Given this list of marker genes ATPAF1, ITCH, COQ5, SNRPD3, TRPC4AP, FBL, SNX19, HAX1, GET4, ENSA, MRPS2, RPA1, SLC35A4 (NCBI Gene Id 113829), COA5 (NCBI Gene Id 493753), GTPBP1, EIF2S2, SMARCA5, PTPN11, TSPYL1, CHMP2B, KRAS, WHAMM, PSMC3, RUVBL1 (RuvB like AAA ATPase 1), SPAG7, DNAJC8, USB1, LTV1, ARFGAP2, QRICH1, POLR1D, TBL1XR1, FLCN (NCBI Gene Id 201163), CDC34 (cell division cycle 34, ubiqiutin conjugating enzyme), PPIB, SENP2, SMARCC1, ARCN1, EMC4, SUB1, BUB3, VPS16 (VPS16 core subunit of CORVET and HOPS complexes), E4F1 (NCBI Gene Id 1877), NFX1, SLIRP, COX15 (NCBI Gene Id 1355), OXSR1, CYB5B, TERF2IP, FAF2, USP39, PSMD7, AK2, IPO9, DHPS, DNAJB6, BSDC1, UBQLN1, FAM168B, C1orf174, NSMCE4A, TIMM22, BORCS7, H2AZ2, EIF3M, CACTIN, JAK1, GNL2, TNKS, FBXO28, NOP14, SF3B2, ERGIC1, STX4, DNAJA1, SEC62, STK24 (serine/threonine kinase 24), PPID, LSM4, APPL1, BTF3, MEA1, OTUD4, MRPS30, HNRNPA1, PRDM4, PA2G4, SCYL2, C11orf98, PRPF38A, EMC6, PRKAA1, WASL, BAP1, SF3B6, UBE2F, UBQLN4, FZR1, FAM168A, SNF8, YARS1, ACBD3, TOMM20, OST4, MIEF1, ATF6B (activating transcription factor 6 beta), AKIRIN1, RANBP1, RALY, TMEM245, TAOK2, MRPL57, ARAF, LSM14A, ZMIZ1, SH2B1, PDAP1, MECP2, DNAJC1 (DnaJ heat shock protein family (Hsp40) member C1), ZNF146, TADA3, EIF4G2, RBM42 (RNA binding motif protein 42), UBE3C, CUL3, BRMS1, TAX1BP1, DCTN3, SENP5, ZNF706, HAPSTR1, EIF2B1, ZNF865, BRK1, ANP32A, EIF3G, USP48, UFL1, SNRNP70, SPG11, PSMA5, DNAJC4, PBX2, VCP, RNF139, GTF3C3, SON, PHRF1, PCGF3, RNF216, DCTN2, CDK4, CSNK2B, TMEM248, TIMM17B, KPNA4 (NCBI Gene Id 84857), ZDHHC6, DHX40, YWHAQ, FEM1B, COMMD7, NMD3, RAD21, COPS5, H3-3B, THOC7, JAGN1, EEFSEC, ERH, SKP1, SNX3, MAX, CHMP4B, MRPL9, LAMTOR5, METTL9, MBD2, MRPL41, WDR45B, SEC13, MCMBP, ZC3H3, KDM4B, DCTN4, C1orf43, RABGGTB, UBE2Q1, GOLGA3, CALR, ARMCX3, PPP1CC, ISCU, NIFK, JOSD1, COA3, HMGXB3, TOMM22, POLR3C, RC3H2, RANBP10, PSMD6, OSTC, SOD1, ATG3, TSR1, NT5C2, CTNNBL1, COASY (Coenzyme A synthase), COPZ1, NDUFB8, UTP18, MYCBP2, MFN2, HSPA4, PDCD7, RALBP1, RAB11A, RHOT2, PLAA, SRPRB, PARK7, FAM98A, PPP1R11, PUF60, ST13, KCMF1, MGRN1, NUMA1, RPL22 (ribosomal protein L22), TMEM203, DDX1, HSP90B1, SP1, ANKRD52, ANKS1A, MRPL51, CDC5L, RBM8A, CLNS1A, NAPG, LCMT1, NGDN, PHF5A, AGGF1, VEZF1, SMAP1, GTF3A, SNRPB, PSMD11, PPP2R1A, MRPL44, ZC3H18, MORF4L2, USP14, DRG1, SNRNP35, MTDH, ABCE1, NSMCE1, MAZ, EIF5B, RBM25, API5, MED4, LRPAP1, POLR2K, GBF1 (golgi brefeldin A resistant guanine nucleotide exchange factor 1), CREBBP, VPS37C, GOLGA4, SLC39A6, PPP2R5A, AAMP, PACS1, CNOT11, GTF2F1, LMF2, CMTR1, MLEC, SMC1A, MRPS16, CLPTM1L, PURB, PNRC2, YTHDC1, DNAJC11, EMC8, LSM12, CTDNEP1, DHX15, GTF2B, NXF1, ARHGAP1 (Rho GTPase activating protein 1), VPS26A, STK38, LONP2, SPPL3, PSMD14, BRD3, CBX1, OTUB1, LAMTOR1, MAPK1IP1L, GDI2, UBFD1, CDKN1B, WAC, TIMM17A, MBD1, AHSA1, CRKL, SF3A2 (splicing factor 3a subunit 2), RRP7A, JTB (jumping translocation breakpoint), TMEM165, AIDA, SP2, SETD5, EIF4A3, DDX17, MRPL36, ATF6, FIS1, IK, PFDN1, RAB35, SRSF11, CBY1, SSR3, FAM32A, SRSF4, EMD, TMEM50A, BZW1, ZMYND19, UBE2Z, TMX4, SNX12, COPB2, MCCC2, MRPL22, SFPQ, AKT1, CHP1, BAG1, ELK1, G3BP2, ERAL1, TBK1, DNTTIP1, RANBP9, LONP1, BRD4, ZFYVE21, LSM14B, MRPS25, CUL4B, GUK1, PPP6C, SLC25A11, PAFAH1B2, RNF113A, EIF3K, USP22, PDS5A, SF3B4, APEH, BUD31, CLPP, MED28, B4GALT7, AARSD1, RRP9, U2AF2, ARF1, HNRNPUL2, MRPL49, TPP2, PREB, CIPC, PTEN, LMAN2, TUBG1, CLPTM1, PIN1, FBXW5, HNRNPA2B1, HSPE1, PELP1, LEMD2, PSMA7, PACSIN2, EIF4H, DDX23, CCT4, UBAC1, SART3, OS9, PABPN1, NUP153, LMAN1, HTATSF1, PSMD8, PAIP1, BET1L, CMPK1, ABCF2, EIF1AX, MSL2, FAM50A, CDC16, TMEM230, RMND5A (NCBI Gene Id 64795), MAU2, SMDT1, ZC3H11A, NAP1L4, NCL, RNF181, RANBP2 (RAN binding protein 2), PBDC1, MMADHC, ILF2, MORC2, TMED10, TPI1, GPX4, SRSF2 (NCBI Gene Id 6427), RAB11B, NAT10, COPS4, BNIP3L, EBNA1BP2, SMPD1, COX17, PSMA6, SLC35E1, KDELR2, PMPCA, SLC25A3, NUDT21, ZRSR2, LARP1, WDR83OS, POLD2, KCTD20, HCFC1, ARFGAP3, GPI, NMT1, ERLEC1, G3BP1, DNAJA3, GOSR2, NGRN, RPL4, SEC24B, ALDH9A1, TSR3, RTCB, DDB1, ATP5PF (NCBI Gene Id 63498), PCIF1, PCSK7, RSRC2, INTS12, NCBP2, ARL8B, SNX27, APH1A, LAMP2, RBM14, PGRMC2, HGS, NUDC, RBCK1, EIF2AK1, EIF1B (NCBI Gene Id 10289), RRAGA, ACAD9 (NCBI Gene Id 96656), TMCO1, SLC25A28, CDC42SE1, AGAP3, MORF4L1, TXNL1, CUTA, PRPS1, WIPI2, SRRM1, NSA2, TAF10, STRAP, ARPP19, RAB14, PSME3, MAN1A2, ZNF593, OGT, PTRH2, STUB1, UBR4, FUBP3, SSNA1, DNAJC7, POLR2J, FCF1, NARS1 (NCBI Gene Id 9243), CDC37L1, PSMB6, COPG1, RER1, PRCC, CAB39, C9orf78, PUM2, NELFB, GTF2F2, MED13 (NCBI Gene Id 9969), INO80, SBDS, RPL15, PGAM5, FKBP8, SRM, SRP14, KDM1A, GTF3C6, UBAP2L, ATP6AP2, ELOF1, TAB1, ERGIC3, PCMTD2, SEC31A, PSMC1, CNBP, TRIM28, ALKBH5, HNRNPAB, PAF1, SLC30A5, ATP6V0E1, DAP3, BTBD1, PARN, SPAG9, ANKFY1, BOD1, CUL1, MEPCE, SNAPIN, LSM1, SEPHS1, PSMD5, TBCA, RPL35A, MRPS17, GSPT1, DENND6A, VPS25, DPY30, CDC23, SAR1A (NCBI Gene Id 56909), CSNK1G2, ZBTB17, SCYL1, ARNT, GID8, NOB1, TMEM256, DDX47, AK3 (NCBI Gene Id 50808), BAZ1B, TCP1, ERP44, RRN3, CTBP1 (NCBI Gene Id 1487), MRPL28, EIF3A, NUCKS1, TMEM42, C6orf120 (chromosome 6 open reading frame 120), RPA2, AP1G1 (adaptor related protein complex 1 subunit gamma 1), PSMD4, HDLBP, ZNF777, EIF3E, NUDT16L1 (NCBI Gene Id 84309), UBE2J1, BANF1, SYF2, HNRNPUL1, EXOC2, HSD17B12, CEBPZOS, MED9, SREBF2, CCT2, EMC2, CFDP1, MAPK1, NFYB, POLR2C, HINT1, HTT, PPP5C, UBL4A, DNAJC5, NAP1L1, G6PC3, SRP9, EIF2D, TXNDC12, GSK3A, MTFR1L, EAPP, MCTS1, CD2BP2 (CD2 cytoplasmic tail binding protein 2), UBE2I, DIMT1, SSR2, SND1, CCAR2, STIM1, MRPS14, UBL7, BLOC1S2, AKIRIN2, DARS1, KHSRP, TBC1D20, SPG7, YME1L1, MAPK8IP3, E2F4, PATL1, MSL1, RING1 (NCBI Gene Id 6015), STIP1, TUSC2, RNF20, TMEM219, AASDHPPT, PARP1, GNPTG, SLC25A5, DNAJC9 (NCBI Gene Id 23234), GATAD2B, RPS19BP1, ILF3, TXN2, PSMC5, GPKOW, KIFBP, PPP6R2, LARS1, FAM20B, PSMG2, TOMM70, PFDN2, ADIPOR2, ARL14EP, TMEM101, VPS52, CNPPD1, CCZ1, DERL1, PNO1, VPS36, ACTR2, MRPL37, FHIP2A, SMAD2, DCAF15, ATG101, EIF4B, NDST1, CSNK2A2, SKIC3, SF1, FBXL3, SMIM12, FIZ1, MRPS28, SH3GL1, TMEM258, LENG8, DEAF1, SYNCRIP, ACTR1B, CCDC97, TCF25, TOR1B, HP1BP3, ARMC1, SDHAF2, CUEDC2, BCAP31, LDB1, DAD1, PRDX5, RAB2A, C14orf119, EDC3, RAB7A, FBXO42, DDX18, IQSEC1, KPNA3, PWP2, AARS1, NUP133, MRPS9, SHARPIN, UGP2, CCDC47, IGBP1, GLE1, SART1, SGTA, KBTBD2, GNB1, TEX261, YWHAB, CTNNB1, TUT1, CGGBP1, PCMT1, PPTC7, PSMD10, PRPF18, KLHDC10, TMED4 (transmembrane p24 trafficking protein 4), CHMP3, C6orf89, SERBP1, CDC123, TMEM127, ANAPC2, PDIA6, PSMD1, DCTPP1, SNX1 (sorting nexin 1), VTI1B, NOP9, KDELR1, STRN4, OSBP, U2AF1, NRBP1, RANGAP1, MRPL14 (NCBI Gene Id 64928), SRSF6, FXR2, PRPF19, CMAS, NOL7, PSMB2, SMIM11, BTBD2, LENG1, SMARCB1, RNF167, AAR2, PSMD3, VPS26B, KHDRBS1, RAB1B, STAU1, WBP4, THRAP3, RSL24D1, KIAA0319L, SURF4, UROD (NCBI Gene Id 7389), SARS1, PRKRA, MRPL18, CSNK2A1, PIGH, CDC37, EEF1D, RAD23B, UBP1, VDAC1, IER3IP1, DYNC1LI1, STAT3, PCYT1A, TNKS2, PPP2R5C, SEC61B, ARL6IP1, RERE, ASNSD1, KEAP1, PSMB7, CDC42, GPBP1, DCAF12, RNF168, RAB5A, CHTOP, PPP1R37, SRSF9, ILKAP, WRNIP1, GNPAT, TARDBP, TRAM1, RAD23A, R3HCC1, TBCD, LYSET, PAFAH1B1 (platelet activating factor acetylhydrolase 1b regulatory subunit 1), YTHDF1, SAV1, EBAG9, RBMX2, GABARAPL2, MYDGF (NCBI Gene Id 80302), MARCHF5, EPN1, LRPPRC, ARF4, SRSF3, COMT, PCYOX1 (NCBI Gene Id 63081), RARS2, ACBD6, SSBP1 (NCBI Gene Id 6742), SLC35A1, CASC3, RALA (NCBI Gene Id 5898), SLC4A1AP, YIF1A, PCBP2, THAP11, SF3B1, HNRNPM, SMU1, NDUFAF2, UBL5, SUPT6H, MED10, ZDHHC7, STK11, GSTO1, CRTC3, COPE, RABL6, EIF3B, RAB6A, HIGD1A, NEDD8, SUGT1, PDCD6, LRRC59, ARPC2, TOLLIP, NFATC2IP, TMBIM6, YIPF3, ADRM1, CCNI, HIPK1, HAT1, GOLPH3, INTS10 (NCBI Gene Id 55174), TMX3, PPT1, ICMT, LUC7L3, UBXN1 (NCBI Gene Id 92151), CCDC22, MRPL24, ANKLE2, PRKAR1A, MRPS10, MRTO4, AP3S2, DENR, CRK (CRK proto-oncogene, adaptor protein), CDC26, BAD, YWHAE, RAC1, LRRC41, TRMT112, BMI1, POFUT1, KAT8, KXD1, KCTD5 (NCBI Gene Id 91152), ANKRD10, SERP1, DNAJC13, AIP, PSMB4, SCAF1, SLC30A9, SAP18 (NCBI Gene Id 10284), ZFP91, FIBP, EIF2S1, MAP2K2, TMEM183A, EMC7, ARL1, TMEM60, MTPN, ACTR1A, SRSF1, NPEPPS, TRIP4, NAPA (NCBI Gene Id 8775), STX8, ZNF330, DDX19A, NUDT9, HNRNPDL, EIF5A, SSU72, VPS29, IPO8, RNPS1, BCCIP, BFAR, CSNK1D, P4HB, PPP2R5E, IWS1, HSP90AB1, MRPS5, ISCA2, ELAVL1, ZRANB2, DYNLRB1, IPO5, HNRNPD, HERPUD2, PDPK1, UTP3, CFL1, TM9SF3, MPHOSPH10, SMYD5, TMEM30A, SARNP, TMED1, NUS1, MAGOH, PWP1, YY1, HSF1, PSMA2, MED25, MTCH1, MTOR, PPP1R15B, COPS6, GATAD1, MLF2, HSBP1, BLTP2, SNRPA, DDX51, CCDC50, TBCB, DNAJB11, EXOSC4, DCAF5, RBX1, PHF12, USP4, TSN, KARS1, SSRP1, PRKAR2A, PREP, MRPL38, UBA1, RPL7L1, FTSJ3, GPN3, MFSD14A, WDR55, EIF3D, GET3, SUMO1, ETF1, VPS51, GFUS, MAPRE1, SPRYD3, ERI3, KPNA6, PIP5K1C, MAEA (macrophage erythroblast attacher, E3 ubiquitin ligase), CEBPZ, PSME3IP1, BTF3L4, NCOA5, CSNK1A1, TMEM259, TADA2B, BAG6, RTF1, POP7, CHMP6, ZC3H15, RPN1, SDF4, DHX38, PSMG3, AMFR, HNRNPU, PSMB1, ANKRD40, COG7 (component of oligomeric golgi complex 7), TRIP12, ARFGEF2, MAP2K1, CHMP2A, SPTSSA, RBM17, UBE2G1, UBA2, COA6, RPN2, GPN2, SF3A3, ZMAT2, DNAJC3, UBE2K, PRPSAP1, PABIR1, LARP4B, DUSP11, EGLN2, PRKCSH, RBM4, CHCHD1, WDR46, AP3M1, MRPL39, CCNK, RRP36, POLE3, PPP2CB, RAB3GAP1, NPLOC4, YKT6, PPP1R8, CAND1 (NCBI Gene Id 55832), BCKDK, ERP29, NCBP1, UBE2D2, TOR1A, ZMPSTE24, ARIH2, RGP1, PCBP1, ADH5, SNAP29, ZYG11B, ZFPL1, NOSIP, FBXW4, PHAF1, SF3B5, CCDC124, AP2M1, PITHD1, RHEB (Ras homolog, mTORC1 binding), MCRS1, UFM1, SRSF10, KDM2A, GGA2, PSMD12, MED21, DNLZ, PDZD11, TXNDC9, DHX29, RHBDD2, STT3B, SLTM, COG3, GORASP2, XPOT, NACA, ZRANB1, DDX27, KPNA1, TMED9, TMEM147, SLU7, MRPL43, GTF2E2, MED19, ELL, EIF4A1, COPA, DNAJA2, TTC1, RAB9A, PPP2CA, EMC3, MRPL17, ASXL1, EIF3I, UBE2R2, PPP6R1, PMPCB, WDR82, FRG1, TRAPPC3, ANP32B, NUFIP2, CALM1, UFC1, PDIA3, MKRN2, STX5, here is a description of the gene set: Human Gene Set: HOUNKPE_HOUSEKEEPING_GENES List of 1130 human and mouse housekeeping genes. This list shows the overlap of human genes stably expressed across 52 tissues and cells types and mouse genes with at least one of their transcripts expressed across 14 tissues and cells types. species: Homo sapiens from publication Hounkpe BW, Chenou F, de Lima F, De Paula EV (PMID 32663312) Housekeeping (HK) genes are constitutively expressed genes that are required for the maintenance of basic cellular functions. Despite their importance in the calibration of gene expression, as well as the understanding of many genomic and evolutionary features, important discrepancies have been observed in studies that previously identified these genes. Here, we present Housekeeping and Reference Transcript Atlas (HRT Atlas v1.0, www.housekeeping.unicamp.br) a web-based database which addresses some of the previously observed limitations in the identification of these genes and offers a more accurate database of human HK genes and transcripts. The database was generated by mining massive human and mouse RNA-seq data sets, including 11 281 and 507 high-quality RNA-seq samples from 52 human non-disease tissues/cells and 14 healthy tissues/cells of C57BL/6 wild type mouse, respectively. Overall, 2176 housekeeping genes have been identified in this study.